The following is a description of a gene set: Type I and type II interferons (IFNs) bind to different cell surface receptors but activate overlapping signal transduction pathways. We examined the effects of a type I IFN (IFN-acon1) and a type II iFN (IFN-g1b) on gene experession in A549 cells and demonstrate that there is a common set of genes modulated by both IFNs as well as a set of gene specifically regulated by each, reflecting the activation of different signaling pathways. In particualr, IFN-g induced many more genes of the signaling pathways, apoptosis, and cytokine interactions than did IFN-a. Even with genes induced by both IFNs there were distinctive quantitativive differences in expression. IFN-g1b plays a major role in the induction and regulation of the complement pathway. Previous work has shown a synergistic antivral and antiproliferative effect of type I and type II IFNs in cell culture and in the treament of tumors in mice. We demonstrate that a majority of genes showed and additive effect of IFN-acon1 and IFN-g1b, but a subset of gene is synergistically induced; these incluce ISG10, MX2, OAS2, and other genes known to be involved in the antiviral response, TRAIL (TNFSF10) and caspases involved in apoptosis and chemokine genes RANTES, CXCL10, and CXCL11. Greater than additive transcription of some of these genes in the presence of both IFNs was confirmed by real-time kinetic RT-PCR. Elevated induction of many of these genes may be sufficient to explain the synergistic antiviral and antitumor effects of this combination of IFNS in vivo. Genes down-regulated in epithelial cells (6h): interferon alpha versus interferon alpha and IFNG. species: Homo sapiens from publication Sanda C, Weitzel P, Tsukahara T, Schaley J, Edenberg HJ, Stephens MA, McClintick JN, Blatt LM, Li L, Brodsky L, Taylor MW (PMID 16800785) Human Gene Set: GSE5542_IFNA_VS_IFNA_AND_IFNG_TREATED_EPITHELIAL_CELLS_6H_DN, and this is the list of marker genes: GNB5, CHRNB1, ABCD3 (NCBI Gene Id 5825), RIGI, RRP36, COX11, ANKMY2, ARFIP1, CUL1, IL10RB (NCBI Gene Id 3588), SPNS1, HS3ST2, CTSF, MAPK9, NKIRAS1, LUZP1, IDH2, FUT11 (NCBI Gene Id 170384), SARS1, FAM204A, CCL13, FAU, FYTTD1, FAM98C, DENND2B, CRACDL, RASEF, AP4M1, ESRRA, GOLPH3L, DOK1, CCSER1, ATP6V0E2, FGG, BTBD3, TMEM245, EIF2B1, OPA1, COL3A1, RHBDL2, THOC7, PER1, SLC25A28, CNOT2, CLDN8, MAP7D1, SLC48A1, CXCL13, CTNS, FOXD2, SHARPIN (SHANK associated RH domain interactor), C9orf85, HTRA2, PCDH1, TNFRSF11A, GNG10, MANF, AP1AR (NCBI Gene Id 55435), ACP6, ZUP1, PATJ, CTSW (cathepsin W), HBP1, CPSF4, PDK1, MFSD4A, STX6, SIRT4, CAMSAP3, GATA3, TRAP1, ADO, PTK2B, RPS27, MESD, STAT5A, LYPD6B, NR2C2AP, MAN2A1, APOL6, CASP12, CD247, FAM20A (NCBI Gene Id 54757), HLA-E (NCBI Gene Id 3133), EMC10, ARFGAP2, IKBKE, SEC63, GAPDHS, IGBP1, TJAP1, CXADR, CORO1C, FGFR2, CIB1, FBXW9, FEM1C, MSRB3, PHF23, SPATC1L, PARP8, MRPL46, DNPEP, IL12B, POMGNT1, SEC24D, GUSB, CYP27B1 (cytochrome P450 family 27 subfamily B member 1), F9, SMOC2, ABL2, GRPEL2 (GrpE like 2, mitochondrial), WDR36, GABRR2, FNIP2, OSGEP, NAB2, PEX13, EI24, NIPSNAP2, PNPT1, XPA, FAM110C, GPR65, CGNL1, NUDT12, RPLP2, CTNNA1, PPIP5K1, MST1R, USP45 (NCBI Gene Id 85015), RBMS2, PRF1, AKR7A2, NIPA1, STAB1, HTR2B, HEPH, GPX2, ELP5, CRYZ, IRS2, NOP56, FBLIM1, B3GLCT, COX19, AMN, UBALD2, EMG1, POGLUT2, DDX59, RTL8C, GSTT2, CPQ, MECR (NCBI Gene Id 554211), GSTA5, IFT57, MRPL15, AQR, ADA, KCNK6, SAR1A, BTF3, KLRG1, MIA3, BAG3, TSPAN7, NDUFC2, FIRRE, MT4, IFITM5 (NCBI Gene Id 387733), PAK4, BCL7B, EIF5A2, TAF4B (TATA-box binding protein associated factor 4b), PYGB, C2orf42, EIF3L (NCBI Gene Id 51386), ALDH18A1, PIGC, TFEC, RNF103, TMEM131, PLCG1, FGR, GPLD1, ATP5F1C, CFAP126, RIPK4, GSTM1, GLUL, RREB1, DLG3, NEDD8, CCN2, RTCA, ESF1, MDM1, OSTM1